Given this list of marker genes CD28, FAM234B, CCDC187, ADCY9, NAP1L1, DCDC1, SULT1C2, ARHGEF7, FAM171A1, POLQ, C5orf22, TNPO1, CNTFR (ciliary neurotrophic factor receptor), CTBP2 (C-terminal binding protein 2), DBNDD1, MTMR11, ADAM33, CLSTN1, RFX3, PDCD10, INTS9, EIF2B1, WTAP, SLC6A17, KDM6B, GAB2, MAP3K13, NPAS3, B3GALT1, EPN2, GNB1, TMEM200A (transmembrane protein 200A), CRAMP1, PRDM6, LIN52, SYNPO2L, GP1BA, SARM1, LRP8, FBXO25, ZNF251, SATB2, LVRN, here is a description of the gene set: Genes predicted to be targets of miRBase v22 microRNA hsa-miR-8052 in miRDB v6.0 with MirTarget v4 prediction scores > 80 (high confidence targets). Human Gene Set: MIR8052 studied in species Homo sapiens from publication Chen Y, Wang X (PMID 31504780)